The following is a description of a gene set: Human Gene Set: GOBP_ENDOSOMAL_TRANSPORT The directed movement of substances mediated by an endosome, a membrane-bounded organelle that carries materials enclosed in the lumen or located in the endosomal membrane. studied in species Homo sapiens, and this is the list of marker genes: UBAP1, RAB5A, CLN5, ARL4C, CHMP7, AP1S1, SRC, WASHC2C, BTBD8, VPS4B, ATP6AP1, MICALL1, ARFRP1, ENTR1, RHOBTB3, SURF4, TOM1, PLEKHA3, BAIAP3, STX10, TRIM27, RNF126, TBC1D5, SGSM2, NF2 (NCBI Gene Id 654093), PLEKHJ1, CHMP2A, RAB6A, VPS13B, SNX31, RDX, RAB17, SQSTM1, VPS53, ANXA8L1, VTA1, VPS37D, CHMP4BP1, DCLK1, RGP1, GOSR1, USP7, DENND5A, KIF16B, LAPTM4B, VPS36, GOLT1B, RAB7A, ARL1 (NCBI Gene Id 400), LEPROTL1, AKTIP (AKT interacting protein), EHD4, ATP9A, ALMS1, SNX9, CHMP1B, AP5Z1, MAGEL2, CHMP4A, TMEM87A, CHMP4B, RBSN, CHMP1A, VPS35L, SLC66A2, RAB29, RUFY4, DENND1A, LYST, UBE2O, ZFYVE9, SNX17, AKAP5, DNAJC13, FHIP1B, RAB6B, LAMTOR1, CORO1A, VPS50, RAB11FIP3, VAMP4, GRIP2, PIK3R4, WASHC5, ITSN2, WASHC2A, ITSN1, RAB35, GRIPAP1, ABCA1, HEATR5A, SNX2, VPS37B, ARF6, EPS15, VPS28, CMTM6, MTMR4, VPS37C, TBC1D10B, SPAG9, EHD1, CLTC, TSG101, VPS51, TMCC1, EPG5, RIC1, RAB6C, VPS26C, SORL1, VCP, RAB11B, BECN1 (NCBI Gene Id 8678), VPS52, TBC1D10C, MVB12B, ACTN2, SORT1, DENND2A, STX16, RAB8A, EZR, DCTN1, HEATR5B, LRRC7, STX5, MTMR2, AP5B1, COMMD1, SNX3, STX6 (syntaxin 6), PHETA2 (PH domain containing endocytic trafficking adaptor 2), NDRG4, VAMP3, SNX6, BLOC1S1, SNX32, SNX4, SNX33, LMAN1, RAB6D, DAB2, ANKFY1, AGAP2, EIPR1, SNX1, SNX18, VPS26A, CALY, EMP2, LMTK2, ARHGAP1, TBC1D10A, TMEM87B, VPS54, TMEM50A, RAB9A, SNX16, VPS26B, PREPL, RAB9B, EVI5 (NCBI Gene Id 7813), PIKFYVE, VPS11, EHD3, SNF8, ARL8B (ADP ribosylation factor like GTPase 8B), CCDC22, STX12, GGA1, SNX27, TRARG1, WDR81, CHMP6, RAB41, BLTP3B, SNX5, PRKN, VPS16, LRRK2, CLTCL1, ERC1, VPS4A, GBF1, GGA3, RAB8B, HOOK3, MAPK3, NSG2, DPY30, RAB10 (NCBI Gene Id 51140), PLA2G4E, WIPF3, VPS35, ANKRD50, MYO5B, TRAPPC10, WASHC4, TINAGL1, TMED9, TBC1D23, MYO1D, EPS15L1, RAB11A, SNX12, RAB11FIP4, VPS25, RAB12, VTI1B, WASHC1, RAB14, TBC1D17, ALS2CL, MSN, LEPROT, EHD2, MVB12A, STX8, AP5S1 (NCBI Gene Id 55317), VPS39, RASSF9, ANXA8, VPS29, ATG14, HGS (hepatocyte growth factor-regulated tyrosine kinase substrate), ARFIP1, BLOC1S2, HOOK2, CHMP2B, MAP2K2, TMEM50B, ZDHHC2, ZFYVE16, MICALL2, DIAPH3, MAPK1, WAS, NSG1, REPS2, PHETA1, RCSD1, PLA2G3, BET1L, UBXN6, CRACR2A, PTPN23, GCC2, DENND1B, AP1G1, SCRIB, DENND10, RILP, YKT6, ARHGAP44, AP3D1, INPP5F, TBC1D14, ACAP2, AP5M1, CORO1C, SNX30, SNX8, GRIP1 (glutamate receptor interacting protein 1), VPS37A, WASH3P, BLTP1, SCARB2, RAB4B, ANKRD27, RAB21, EEA1, CHMP5, RUFY1, PICALM, DYNC1LI1, RAB13, CHMP3, HOOK1, CHMP4C, PIK3C3, CLEC16A, STAM2, REPS1, ARHGAP8, MAP2K1, WDR91, SNX7, ALS2, WASH6P, RAB7B, VTI1A, GOLT1A, BVES, CCDC93, STAM, WASHC3, DENND1C